Given this list of marker genes DIAPH3, MYO7A, WHRN (NCBI Gene Id 8016), VEZT, USH2A, USH1C, ADGRV1, PDZD7, here is a description of the gene set: A structure involved in coupling stereocilia to one another in sensory hair cells There are four morphologically distinct types: tip links, horizontal top connectors, shaft connectors and ankle links. Tip links and horizontal top connectors are the only inter-stereocilia links associated with mature cochlea, whereas ankle links appear during development of the auditory hair bundle. species: Homo sapiens Human Gene Set: GOCC_STEREOCILIA_COUPLING_LINK